The following is a description of a gene set: Mouse Gene Set: REACTOME_BIOSYNTHESIS_OF_MARESINS studied in species Mus musculus Biosynthesis of maresins, and this is the list of marker genes: Cyp3a41a, Cyp3a59, Cyp3a16, Cyp3a25, Cyp3a57, Cyp3a41b, Cyp3a13, Ephx2, Cyp2d22, Cyp3a11, Cyp2e1, Cyp2c65 (NCBI Gene Id 72303), Cyp2c66, Cyp1a2, Cyp3a44, Alox5